Given this list of marker genes NKIRAS2, GNPAT, TSKU, THAP1, MIR503HG, RPRD2, SFPQ, RPS27, RALA, SMYD5, JADE2, CNOT3, NDST2, TSC22D2, LINC01465, MAEA, C1orf131, DHX15, SF1, TPGS2, KDM2A, ASH1L, PABPN1, SLC39A9, TNKS2, BABAM1, RCC1L, HNRNPD, MAML1, CIPC, EEF1A1, PSMB5, VAMP2, MTFP1, TOP3A, CPNE1, TEPSIN, CD3E (CD3 epsilon subunit of T-cell receptor complex), ESCO1, UBXN11, ZMYM2, RAB22A, SMC3, ZBED5, TSC1, PAX2, NUS1, PSMD8, NCDN, PCNT, KIF15, DDX6 (DEAD-box helicase 6), FKRP, COX20, MRPL38, EIF5, POU2F1, CCND1, NEUROD2, GBF1, DOLK, NFYA, MYNN, ZFP37 (NCBI Gene Id 7539), REST, INKA1, PRPF38B, UBE2J2, HMGB3, C2CD5, CBX5, ARCN1, DCAF8, PRPSAP1, SRRM4, EXOC6, PRMT1, ATP5PD, BMI1, PICALM, CHD2 (NCBI Gene Id 283680), H1-0, LRRC41, ASB2, RBM19, RBM4, CERT1, USF1, ODAD3, CPSF2, SRRM1, ARNT (aryl hydrocarbon receptor nuclear translocator), PRRC2C, AP3D1, PIGN, ATF4, EIF3A, OARD1 (O-acyl-ADP-ribose deacylase 1), BCLAF1, WDR33, NFYC, HNRNPA1, RAB1A, EIF4G2, ARF1, SMC4, PCF11, EXT1, PPRC1, RBM3, NCOR1, PIAS3, MIOS, KDM5C, RFX3, APBB3, ZC3H11A, CDH23, FBXO11, UBIAD1, ZFP91, UBR5, MID1, CLK1, UBE4B, FASTK, INTS7, ODF2, CSAD, XPR1, VDAC2, PPP4R3B, ZFX, SERBP1, RAD23A, DGCR2, WDR77, TIA1, RPL35A, ZC3HC1, DEAF1, PIGL, CCAR1, TMEM187, APBB1, RBM15B, CLSTN1, YY1AP1, REXO1, PCIF1, NACA, LUC7L3, OLFML3, CSNK1A1L, ATP5PB, C19orf48P, NDUFA4L2, RIF1, CELF1, NDUFB1, EP300, HMGXB4, SNAP25, RBM5, DZIP1, SLC35A4, BCL11B, ATP13A1, PRKCSH, CSTF2T, PCBP4, ZFY, GNL3L, SUV39H2, DNAJC7, PRMT6, SNX13, PPP1R15B, RPA2, FHIP1B, ZIC3, HOXA2, PHC3, TMEM80, ZNF207, POLK, ZZEF1, WASL, EPC1, KDM6A, ATF1, HSALR1, CD4, KIAA1143, OSR1, RPL30, ZBTB22, RAC1, CHTOP, C21orf58, ATP6V0C, YY1, IRAK1, PTBP2, RABL6, RBM12, DYNC1H1, MARK3, ATP5MC2, CYB5D2, CCNE1, UBE2D3, CCDC71L, OTX2, HNRNPH3 (NCBI Gene Id 3189), ERH, E2F6, SEPTIN7, MIRLET7BHG, E4F1, PTGR3, PRPS1, RNF26, UQCRH, STAG1, PHF8, PPP1R12B, BRD3, MED1, SNRPF, SMCR8, ENSA, DAP3, GIGYF2, SLAIN1, PBX3, NASP, RIOK3, USP48, TRA2B, ADK, GABPB2, NSD1, ZNF644, TCF4, CCDC186, ACTR8, PPP1CC, STRN4, BAHD1, RPAP1, here is a description of the gene set: species: Homo sapiens Genes having at least one occurrence of the motif CGGCCATCT in the regions spanning 4 kb centered on their transcription starting sites. This matches the transcription factor binding site V$NFMUE1_Q6 (v7.4 TRANSFAC). Human Gene Set: NFMUE1_Q6